Given this list of marker genes USP10, PTRH1, SKIC2, LTN1, RACK1, TCF25, ZNF598, MTRFR, PELO, UFL1, KLHDC10, CDK5RAP3, MRPL58, ABCE1 (ATP binding cassette subfamily E member 1), RNF14, GTPBP2, RNF25, SKIC8, MTRES1, SAYSD1, SKIC3, NEMF, DDRGK1, ANKZF1, ASCC3, ASCC2, EIF4E2, GCN1, UFSP2, TRIP4, TRNT1, RCHY1, GIGYF2, HBS1L, ELAC1, here is a description of the gene set: Human Gene Set: GOBP_RESCUE_OF_STALLED_RIBOSOME A process of translational elongation that takes place when a ribosome has stalled during translation, and results in freeing the ribosome from the stalled translation complex. species: Homo sapiens